The following is a description of a gene set: Human Gene Set: HU_GENOTOXIN_ACTION_DIRECT_VS_INDIRECT_24HR Genes discriminating between direct (cisplatin, MMS, mitomycin C) and indirect (paclitaxel, hydroxyurea, etoposide) acting genotoxins at 24 h time point. species: Mus musculus from publication Hu T, Gibson DP, Carr GJ, Torontali SM, Tiesman JP, Chaney JG, Aardema MJ (PMID 15120960) During the safety evaluation process of new drugs and chemicals, a battery of genotoxicity tests is conducted starting with in vitro genotoxicity assays. Obtaining positive results in in vitro genotoxicity tests is not uncommon. Follow-up studies to determine the biological relevance of positive genotoxicity results are costly, time consuming, and utilize animals. More efficient methods, especially for identifying a putative mode of action like an indirect mechanism of genotoxicity (where DNA molecules are not the initial primary targets), would greatly improve the risk assessment for genotoxins. To this end, we are participating in an International Life Sciences Institute (ILSI) project involving studies of gene expression changes caused by model genotoxins. The purpose of the work is to evaluate gene expression tools in general, and specifically for discriminating genotoxins that are direct-acting from indirect-acting. Our lab has evaluated gene expression changes as well as micronuclei (MN) in L5178Y TK(+/-) mouse lymphoma cells treated with six compounds. Direct-acting genotoxins (where DNA is the initial primary target) that were evaluated included the DNA crosslinking agents, mitomycin C (MMC) and cisplatin (CIS), and an alkylating agent, methyl methanesulfonate (MMS). Indirect-acting genotoxins included hydroxyurea (HU), a ribonucleotide reductase inhibitor, taxol (TXL), a microtubule inhibitor, and etoposide (ETOP), a DNA topoisomerase II inhibitor. Microarray gene expression analysis was conducted using Affymetrix mouse oligonucleotide arrays on RNA samples derived from cells which were harvested immediately after the 4 h chemical treatment, and 20 h after the 4 h chemical treatment. The evaluation of these experimental results yields evidence of differentially regulated genes at both 4 and 24 h time points that appear to have discriminating power for direct versus indirect genotoxins, and therefore may serve as a fingerprint for classifying chemicals when their mechanism of action is unknown., and this is the list of marker genes: PTP4A1, TNFRSF18, GLRX3, INCENP, MIF4GD, TOMM34, UBXN11, CREB3L1, UBE2E1, SLC50A1, HS1BP3, SYNCRIP, STRN, NUBP1, TINF2, C4A, MST1, TOP2A, NPM1, DNAJB6, IFT25, ATP5F1C (ATP synthase F1 subunit gamma), RBBP7, NUS1, PAG1, PSMA2, LYPLA2, CCT3, G3BP2, H2AC8, RTCB (RNA 2',3'-cyclic phosphate and 5'-OH ligase), API5, APEX1, KRT4, RB1, HDAC6, GSTM5, RIC8A, MTDH, JUNB, NCL, IPP, NELFE, YPEL3, FCHO1, PTMA, EMP3, FASTK, HSD3B1, HLA-B, HNRNPUL2, SOWAHC